The following is a description of a gene set: from publication Fu W, Ergun A, Lu T, Hill JA, Haxhinasto S, Fassett MS, Gazit R, Adoro S, Glimcher L, Chan S, Kastner P, Rossi D, Collins JJ, Mathis D, Benoist C (PMID 22961053) species: Homo sapiens Genes up-regulated in CD4 T conv: control versus over-expression of SATB1 and FOXP3. The transcription factor FoxP3 partakes dominantly in the specification and function of FoxP3+ CD4+ T regulatory cells (Tregs), but is neither strictly necessary nor sufficient to determine the characteristic Treg transcriptional signature. Computational network inference and experimental testing assessed the contribution of several other transcription factors (TFs). Enforced expression of Helios or Xbp1 elicited specific signatures, but Eos, Irf4, Satb1, Lef1 and Gata1 elicited exactly the same outcome, synergizing with FoxP3 to activate most of the Treg signature, including key TFs, and enhancing FoxP3 occupancy at its genomic targets. Conversely, the Treg signature was robust to inactivation of any single cofactor. A redundant genetic switch thus locks-in the Treg phenotype, a model which accounts for several aspects of Treg physiology, differentiation and stability. Human Gene Set: GSE40274_CTRL_VS_FOXP3_AND_SATB1_TRANSDUCED_ACTIVATED_CD4_TCELL_UP, and this is the list of marker genes: MPP7, CD69, RAB8B, TAF5L, RAI14, BRCC3, NLE1, NRIP1, DNAAF10, SLC15A2, SYTL3, MRPS14, XRN2, CD96, TPRKB, DIMT1, STK39, SDHAF3, IFI35 (interferon induced protein 35), CDCA5, HAX1, HSPB1, BATF, DKC1, ITGB1, CUL5, FARP1, WTAP, CLNK, CDCA2, CYP51A1, SMN1, NOP16, PSMC5, SRFBP1, DDX60, NEK8, GLS (glutaminase), PRRG4, TRIM21, FRMD4B, UTP15, HAUS6, EIF2S1, PSMD12, REXO2, GVINP1, MUL1, TMC3, GIMAP4, MX1, LRRC59, PRKCQ, MYOF, ATP2B1, MTAP, TMEM97, SSU72, CFLAR, FCRL5, SBF2, PLXND1, TNFRSF13B, SERPINB9, VAPA (NCBI Gene Id 9218), TMEM41B, UBXN4, PCBP4 (poly(rC) binding protein 4), MYO1F, UCHL5, HMGN3, PSME3, SUZ12, FIGNL1, MICU3 (mitochondrial calcium uptake family member 3), TRMT12, SLBP, NUP54, GBP5, MTREX, NDUFS6, MARCKS, UBE3A (NCBI Gene Id 7337), SPRED1, RASGEF1B, ITGB1BP2, GPS1, NKG7, BCL6B, SNORD52, GART, MMADHC (metabolism of cobalamin associated D), KTI12, NFIL3, HK2, AGPAT5, MFSD14A, UBA5, CORO2A, SLC25A19, KLHL2, TUFM, ERLIN1, TLR7, ATP10D, SMPDL3B, ITGAL, MRPL36, HNRNPK (heterogeneous nuclear ribonucleoprotein K), FANCA, ZRANB1, NOP2, CD83, NAB1, RUFY3, MIS12, APOOL, ZNFX1, SPO11, RBBP8, LAD1, EIF4E, TRIM5 (tripartite motif containing 5), STARD4, DGAT2, ST3GAL4, SRPK1, UTP14A, RAN, MSANTD2, INO80C, RBM34, RPF1, GPR183, SEC23B, CD47 (CD47 molecule), ACTN2, EOMES, SLC25A33, NOL8, XPO5, SLAMF7, KLF12, NXT1, LRP11, SKP1, CALU, PRDX1, TCERG1, CSNK1D, DDX19A, CINP, MRM3, STX18, PSMC4, RBM27, WDR74, GRHL1, SNORD58B, CRYBG1, CKS1B, USP1, NMI, CCR4, LYAR, CEP83 (centrosomal protein 83)